The following is a description of a gene set: studied in species Homo sapiens Human Gene Set: GOBP_NEGATIVE_REGULATION_OF_TRANSFORMING_GROWTH_FACTOR_BETA_RECEPTOR_SIGNALING_PATHWAY Any process that stops, prevents, or reduces the frequency, rate or extent of any TGF-beta receptor signaling pathway., and this is the list of marker genes: ONECUT1, SKI, WNT1, HDAC1, WFIKKN2, HTRA3, MIR93, FKBP1C, ADAMTSL2, MIR9-1, TP53, NKX2-1, CHST11, MIR323A, SLC2A10, FAM89B, VEPH1, DAND5, USP15, MIR15B, GLG1, LDLRAD4, EID2, ARID4B, ENG, BAMBI, SKOR2, ASPN, MIR498, MIRLET7A1, PIN1, HSPA5, SNX6, MTMR4, SINHCAF (SIN3-HDAC complex associated factor), PPM1A, PRDM16 (PR/SET domain 16), IL17RD, TET1, CIDEA, CAV2 (NCBI Gene Id 858), INTS9, SKIL, STUB1, MIRLET7F1, NRROS (negative regulator of reactive oxygen species), STRAP, FKBP1A, SPRY2, SAP130, MIR342, CD109, MIR19B1, MIR27B, BCL9L (NCBI Gene Id 283149), MIR142, MIR204, HDAC2, LRRC32, MIR20A, SMURF2, MIR361, MIR497, ZBTB7A, MIR181A2, CILP, PDPK1, MIR199A1, ING2, SUDS3, XBP1, ARID4A, MIR564, ZNF451, SNX25 (NCBI Gene Id 83891), SAP30, ING1, BMP2, MIR17, SMAD6, MIR520C, MIR18A, PPARA, MIR373, MIR106A, HSPA1A, MIR372, MIRLET7G, LEMD3, MIR302B, BRMS1L, MIR140, RBBP4, PEG10, MECOM, MIR145, HTRA4, CDH3, FBN1, SPRED3, SPRY1, SMURF1, MIR424, RASL11B, MIR98, SPRED2, SAP30L, BRMS1, SMAD7, ADAM17, PMEPA1 (NCBI Gene Id 56937), MIR490, VASN, WFIKKN1, MIR29B1, MIR19A, RBBP7, HTRA1, SPRED1, OVOL2, GDF15, SIRT1, FBN2, PPARG, EMILIN1, OGT, MIR376C, TGFBR3, MIR101-1, MIRLET7B, LTBP1, SIN3A, PBLD, ONECUT2